Given this list of marker genes COMT, POLR1B, LGI1, NF2, MT-TQ, TBX1, SMARCA2, DNM1L, SMARCAL1, TREX1, COL1A1, STS, RELN, MT-TS2, PLP1, RAI1, MT-TH, GJB1, MT-TW, CHMP2B (NCBI Gene Id 7877), NPPA, HTRA1, DEPDC5, OCRL, MT-ND5, COL1A2, GRIN2A (glutamate ionotropic receptor NMDA type subunit 2A), NPRL2, TCOF1, TIA1, ARVCF, MT-CO2, APOE, CFHR1, SQSTM1, KCNC2, MAPT, L1CAM, SEC24C, HIRA, MT-TL1, PRRT2, FA2H, HLA-DQB1, CFHR3, ADA2, FRRS1L, PSEN1, CYLD, TMEM106B, MT-TF, NSDHL, NPRL3, SCN5A (sodium voltage-gated channel alpha subunit 5), FGFR1, PSEN2, NDUFB11, UBTF, TOMM40, ADAMTSL2, TCF4, PLEC (plectin), ATP1A2, ATRX (NCBI Gene Id 6475), PRNP, GRN, VCP, RREB1, MT-ND4, FLCN, EHMT1, CFH, ADAMTS2, JMJD1C, CACNA1A, HCCS, TREM2, NDUFA1, MT-CO3, FAS, UFD1, MT-ND1, CKAP2L, SORL1, POLR1D, PTPN22, SCN1A, APP, POLR1C, L2HGDH, MT-ND6, ACTG1, SETBP1, ABCA7, COX7B, AMER1, KRAS, GP1BB, HNRNPA1, ACTB, MT-CO1, HNRNPA2B1, NOTCH3, here is a description of the gene set: An acquired language impairment of some or all of the abilities to produce or comprehend speech and to read or write. Human Gene Set: HP_APHASIA Aphasia studied in species Homo sapiens